Given this list of marker genes Abca7, Agap2, Hnrnpk, Washc1, Gpd1l, Stx4a, Akt1, Tnf, Tyrobp, Map1a, Synj2bp, Commd1, Abca12 (ATP-binding cassette, sub-family A member 12), Lrig2, Stx3, Snx33 (sorting nexin 33), Tm9sf4, Erbb4, Tmem35a, Hsp90ab1, Fcer1g, Ric3, Ephb2, Cd247, Rangrf, here is a description of the gene set: studied in species Mus musculus Any process that activates or increases the frequency, rate or extent of protein localization to the cell surface. Mouse Gene Set: GOBP_POSITIVE_REGULATION_OF_PROTEIN_LOCALIZATION_TO_CELL_SURFACE